Given this list of marker genes NFKBIZ, INTS6, RTL3, CSNK1A1L, MBNL3, CIITA, RIMS2, PGM1 (NCBI Gene Id 5236), IGFL2, KCTD5, PHACTR2, BAZ2B, POU3F2, TRIM23, UGT8, TFRC, PIKFYVE, EPYC, BBX, RAB3C, ABCA1, NECAB1, SH3GLB1, YTHDF1, NPTXR, GALNT3, TMEM41B, NIBAN1, GNPAT, SATB2, LDLRAD4, SLC7A11, MIER3, SBF2, ITGA6, DNAH8, ITGA8, TECRL, CRISP3, PLAU, JMJD1C, ANKRD29, CNOT6L, SYPL1, FAM149B1, EPB41L4A, COL6A6, AMMECR1L, OPN3, ST8SIA3, RNF44 (ring finger protein 44), PCDH15, KATNBL1, SAMD4A, TRPV2, OAZ2, MYH11, ROBO2, NECTIN3, COBL, DNAJA3, NIPA2, MUC7, ABHD17C, RANBP3L, KIFBP, MBTD1, ZC3H13, LPIN2, FGF2, RAPGEF4, RALGPS1, CCNT2, DGKK, STX11, IBTK, PSMC2, RBM39 (NCBI Gene Id 9584), APPBP2, SMARCA5, RUNX1, ZNF311, COLEC10, RC3H1, FUT9, EPHA7, GLB1, ERMN, AAK1 (AP2 associated kinase 1), CNTNAP5, TMEM245, PIK3CA, CDH2, GDNF, GPR137C, CAMSAP1 (NCBI Gene Id 55490), CXCL6, KDM7A, LRRC58, CSRP1, HSD17B13, FAM170B, FRZB, SP3, SBSPON, NIPBL, RAB1A, ECM2, PRKCQ, EBF3, DTL, GBX2, PKD1L1-AS1, TEX12, DEGS1, MSRB2, CLIC4 (chloride intracellular channel 4), ARAP2, DIP2C, INPP4A, GUF1, MCM9, ZFAND3, AKT3, ZNF367, THAP2, ISL1, KCNN2, PROM1, MGARP (NCBI Gene Id 84709), STXBP4, EDEM3, VASH2 (NCBI Gene Id 79805), VPS13B, DCN, ERO1A, SLC1A2, CMTM3, FBXW2, AKAP12, G2E3, ADRA2A, CLEC10A, TRAK1, MEOX2, SCAI, MSL2, HOXC8, NUMB, MCCC2, ADGRG2, CAMTA1, here is a description of the gene set: from publication Chen Y, Wang X (PMID 31504780) Genes predicted to be targets of miRBase v22 microRNA hsa-miR-3606-5p in miRDB v6.0 with MirTarget v4 prediction scores > 80 (high confidence targets). studied in species Homo sapiens Human Gene Set: MIR3606_5P